Given this list of marker genes Rnf111 (ring finger 111), Wwtr1, Mapk3, Cdk8, Tfdp1, Smad7, Smad3 (SMAD family member 3), Rps27a (ribosomal protein S27A), Ubb, Men1, here is a description of the gene set: Reactome Pathway: SMAD2/SMAD3:SMAD4 heterotrimer regulates transcription electronically inferred by orthology from the curated human pathway This event has been computationally inferred from an event that has been demonstrated in another species.<p>The inference is based on the homology mapping from PANTHER. Briefly, reactions for which all involved PhysicalEntities (in input, output and catalyst) have a mapped orthologue/paralogue (for complexes at least 75% of components must have a mapping) are inferred to the other species. studied in species Mus musculus part of: Transcriptional activity of SMAD2/SMAD3:SMAD4 heterotrimer